The following is a description of a gene set: Mouse Gene Set: GOBP_POSITIVE_REGULATION_OF_SIGNALING_RECEPTOR_ACTIVITY Any process that activates or increases the frequency, rate or extent of signaling receptor activity. species: Mus musculus, and this is the list of marker genes: Rwdd1, Hif1a (NCBI Gene Id 15251), Bud31, Grem1, Park7 (NCBI Gene Id 57320), Adra2c, Hdac6 (NCBI Gene Id 20374), Nlgn3, Cdk5r1, Edn1, Hfe, Adra2a, Neurl1a, Adam17, Hdac2, Reln, Adrb2, Il19, Hdac1, Fbxw7, Il24, Il20, Thap11, Adra2b, Il10